The following is a description of a gene set: Mouse Gene Set: GOMF_POTASSIUM_ION_LEAK_CHANNEL_ACTIVITY studied in species Mus musculus Enables the transport of a potassium ion across a membrane via a narrow pore channel that is open even in an unstimulated or 'resting' state., and this is the list of marker genes: Kcnk10, Kcnk15, Kcnk4, Kcnk1, Kcnk9, Kcnk13, Kcnk18, Kcnk16, Kcnk5, Kcnk3, Tmem175, Kcnk12, Kcnk2, Kcnk6, Kcnk7